Given this list of marker genes HDLBP, FAM3D, ERN2, PIK3C2G, NFKBIZ, IL33, HMGCS2, THSD4, PLCB4, SOX4, PIGR, LTF, FOXP1, SPDEF, FMOD, ARSD, CDKN1C, RHOBTB1, TCEA3, MECOM, ARHGAP18, CXADR, ADAM28, PDIA2, SLC12A2, TTC3, ZNF395, LIPF, APP, JUN, MUC6, FUT9, ANKRD50, EGR1, CA9, TMT1A, PALM3, NR2F2, PTPRZ1, AKAP9, FOSB, NFIB, LINC00261, SEC62, FOS (NCBI Gene Id 2353), ASPH, IER2, EPHB3 (NCBI Gene Id 2049), MAGI1, GOLGB1, SLC4A4, NBEAL1, ENAH (ENAH actin regulator), PABPC4 (NCBI Gene Id 8761), XYLT2, ATF4, GADD45B, SRRM2, PGC, RGMB, here is a description of the gene set: Human Gene Set: BUSSLINGER_GASTRIC_PREZYMOGENIC_CELLS from publication Busslinger GA, Weusten BLA, Bogte A, Begthel H, Brosens LAA, Clevers H (PMID 33691112) studied in species Homo sapiens